Given this list of marker genes CTNNB1, FGF8, CITED1, HS3ST3A1, FGF2, SMO, PAX2, HOXB7, PAX8, MYC, GREB1L, PKD2 (polycystin 2, transient receptor potential cation channel, NCBI Gene Id 5311), NOG, CTNNBIP1, SOX8, HOXD11, LAMA5, GLI3, ADAMTS16, AGTR2, HS3ST3B1, OSR1, BMP4, SMAD4, SHH, WNT4, FGF1, GREM1, DLG1 (NCBI Gene Id 1739), GDNF, BCL2, FOXD1, GATA3, WNT9B, LGR4, VEGFA, LZTS2, NPNT, TMEM59L, HOXA11, WNT2B, WNT6, GZF1, TGFB1 (transforming growth factor beta 1), SIX1, SALL1 (NCBI Gene Id 6299), GPC3, TACSTD2, PBX1, TCF21, MAGED1, HS2ST1, WT1, LHX1, KIF26B, DCHS1, EYA1, BMP2, HNF1B (NCBI Gene Id 6928), ILK, WNT11, SOX9, PTCH1, SIX4, AGT, HES1, SIX2, WNT1, here is a description of the gene set: The process in which the anatomical structures of a mesonephric tubule are generated and organized. A mesonephric tubule is an epithelial tube that is part of the mesonephros. species: Homo sapiens Human Gene Set: GOBP_MESONEPHRIC_TUBULE_MORPHOGENESIS